Given this list of marker genes CD320, TCN2, ABCC1, AMN, LRP2, ABCD4, CBLIF, CUBN, TCN1, here is a description of the gene set: studied in species Homo sapiens The directed movement of cobalamin (vitamin B12), a water-soluble vitamin characterized by possession of a corrin nucleus containing a cobalt atom, into, out of or within a cell, or between cells, by means of some agent such as a transporter or pore. Human Gene Set: GOBP_COBALAMIN_TRANSPORT